The following is a description of a gene set: from publication Pomeroy SL, Tamayo P, Gaasenbeek M, Sturla LM, Angelo M, McLaughlin ME, Kim JY, Goumnerova LC, Black PM, Lau C, Allen JC, Zagzag D, Olson JM, Curran T, Wetmore C, Biegel JA, Poggio T, Mukherjee S, Rifkin R, Califano A, Stolovitzky G, Louis DN, Mesirov JP, Lander ES, Golub TR (PMID 11807556) Top up-regulated marker genes for medulloblastoma classification: desmoplastic vs classic morphology. Embryonal tumours of the central nervous system (CNS) represent a heterogeneous group of tumours about which little is known biologically, and whose diagnosis, on the basis of morphologic appearance alone, is controversial. Medulloblastomas, for example, are the most common malignant brain tumour of childhood, but their pathogenesis is unknown, their relationship to other embryonal CNS tumours is debated, and patients' response to therapy is difficult to predict. We approached these problems by developing a classification system based on DNA microarray gene expression data derived from 99 patient samples. Here we demonstrate that medulloblastomas are molecularly distinct from other brain tumours including primitive neuroectodermal tumours (PNETs), atypical teratoid/rhabdoid tumours (AT/RTs) and malignant gliomas. Previously unrecognized evidence supporting the derivation of medulloblastomas from cerebellar granule cells through activation of the Sonic Hedgehog (SHH) pathway was also revealed. We show further that the clinical outcome of children with medulloblastomas is highly predictable on the basis of the gene expression profiles of their tumours at diagnosis. species: Homo sapiens Human Gene Set: POMEROY_MEDULLOBLASTOMA_DESMOPLASIC_VS_CLASSIC_UP, and this is the list of marker genes: OLFM1, PDE4C, F8A1, CBX5, GNB3, LDHA, ILVBL, POLR2F, COL2A1, PLEC, TGFB3, GABRG2, ARL4D, POLR2J, ALDOA, CHI3L1, CPOX, SURF1, FPR1, SLC1A2, FLT3LG, BCAP31, BSG, APLP1, NEUROG1, AANAT, SCAF11, TP53BP2, PRDX1, E2F1, CITED1, SUSD6, GPX4, DYRK4, SEPTIN8, CDKL5, KDM5D, KANK1, CRABP2, CHRM4, STX3, ARL6IP1, SMAD2, UGCG, DLX4, THBS4, ATP1B2, PPP2R1B, ABL2, GABRB3, TMEM11, HSP90AA1, LHX2, RPN2, LRP8, SMAD5, NUCB1, USP11, CFHR2, PSMB5, ACLY, MYL5, NOMO1